The following is a description of a gene set: Any process that modulates the frequency, rate or extent of an ATPase-coupled calcium transmembrane transporter activity. Human Gene Set: GOBP_REGULATION_OF_ATPASE_COUPLED_CALCIUM_TRANSMEMBRANE_TRANSPORTER_ACTIVITY species: Homo sapiens, and this is the list of marker genes: STRIT1, TLR9, PLN, VMP1 (NCBI Gene Id 81671), ATP2A1, SLN